The following is a description of a gene set: Combining with a Wnt protein and transmitting the signal across the plasma membrane to initiate a change in cell activity. species: Mus musculus Mouse Gene Set: GOMF_WNT_RECEPTOR_ACTIVITY, and this is the list of marker genes: Fzd6, Fzd7, Lrp6, Fzd8, Fzd9, Fzd2, Ryk, Pkd1, Ror1, Tspan12, Fzd3, Fzd5, Lrp5, Fzd4, Fzd1, Fzd10